Given this list of marker genes DLG3, HOXC4, SPDYE6, GALNT12, PAK5, UQCRB, HRH4, SPDYE1, ZFP69, ZNF704, ZC2HC1C, EIF2S1, ARG2, MATN3, TLCD4, TENT2, MAP2K5, THEMIS, GUCY1A2, ZNF281, YTHDF2, TRIM10, TCF12, CORO1C, PCDH7, LHFPL2, TNRC6B, KLHL1, MICOS10, MBNL1, LAMP2, CLSTN2 (NCBI Gene Id 64084), PTBP3, UHRF2, ARHGDIB, TMEM144, BBOF1, SIPA1L2 (NCBI Gene Id 57568), EHMT1, MYBPC2, NFIB, ANAPC10, B3GALT1, F5, KHSRP, PTP4A2 (NCBI Gene Id 8073), ZNF492, CNR1, AFM, DAAM1, MSL2, TBCK, XPNPEP1, MSX1, SLC1A2, CYLD, SUB1, ZBTB20, IRAK1BP1, TRMT10C, FAM221A, CHN2, CCDC184, VLDLR, HKDC1, FCGR2B, FAM89A, AKAP1, KIAA1191, ZBTB10, IL1RAP, SULF1 (NCBI Gene Id 23213), NEGR1, ZC3H12D, LARGE1, PALM2AKAP2, CNTNAP4, SRGAP3, PKN2 (NCBI Gene Id 5586), NR4A3, SLC18A2, DEFB132, PRKD1, WDR1, SLC25A30, PRMT8 (NCBI Gene Id 56341), AKIRIN1, RAB33B (NCBI Gene Id 83452), XXYLT1, ENO4, PKD2, EMC4, MMGT1, SERAC1, ARMC8, OSBPL11, VCF1, PDE10A, JPH1, UBR5, TRIM71, CPNE4, CNTN5, ITGA7, RPS6KC1, DNAJC11, PURG, GPC6, KANK2, BEND6, RETREG3, RORA, TUBGCP4 (tubulin gamma complex component 4), ZNF98, B4GALT5, RRP8, CDH12, MTHFR, FABP2, SDC2, PLCD4, LRRTM3, FRRS1, AMACR, EPPIN-WFDC6, PRDX1, YWHAG, PPP4R3B, SNX9, SPDYE5, KLF3, NOG, MID2, TAL1, POLR3B, STX6, ATXN7, QKI, OPN5, ACP3, PHLDA1, ZNF275, LLCFC1, ABCD3, here is a description of the gene set: from publication Chen Y, Wang X (PMID 31504780) Genes predicted to be targets of miRBase v22 microRNA hsa-miR-7156-5p in miRDB v6.0 with MirTarget v4 prediction scores > 80 (high confidence targets). Human Gene Set: MIR7156_5P species: Homo sapiens